Given this list of marker genes DCUN1D3, PTPRC (protein tyrosine phosphatase receptor type C), EGR1, XRCC2, LIG4, XRCC6, SOD2, BAK1, TMEM109, ATR, BRCA2, YAP1, BCL2L1, GATA3, CXCL10, RPL26, ZMPSTE24, CYBA, PRKAA1, KDM1A, GPX1, FANCD2, TP53, GTF2H5, TLK2, ATM, APOBEC1, BAX (NCBI Gene Id 581), BCL2, HRAS, ELK1, MIR21, XRCC5, PARP1, PML, ERCC6, TOP1, TREX1 (three prime repair exonuclease 1), RAD51, PRKDC, HSF1, CBL, MEN1, TIGAR, TSPYL5, MAP3K20, POLB, WRN (NCBI Gene Id 7486), CCL7, CRYAB, CDKN1A, MDM2, CHEK2, here is a description of the gene set: Any process that results in a change in state or activity of a cell or an organism (in terms of movement, secretion, enzyme production, gene expression, etc.) as a result of a gamma radiation stimulus. Gamma radiation is a form of electromagnetic radiation (EMR) or light emission of a specific frequency produced from sub-atomic particle interaction, such as electron-positron annihilation and radioactive decay. Gamma rays are generally characterized as EMR having the highest frequency and energy, and also the shortest wavelength, within the electromagnetic radiation spectrum. species: Homo sapiens Human Gene Set: GOBP_RESPONSE_TO_GAMMA_RADIATION